The following is a description of a gene set: species: Homo sapiens Human Gene Set: MIR548AR_5P Genes predicted to be targets of miRBase v22 microRNA hsa-miR-548ar-5p in miRDB v6.0 with MirTarget v4 prediction scores > 80 (high confidence targets). from publication Chen Y, Wang X (PMID 31504780), and this is the list of marker genes: SLC24A3, ADGRB3, LRRC7, ERC2, TMEM200A, SCN3A, BTG3, PTBP3, RAB8B, ZNF559, TMEFF2, UNC80, BBS10, NRG4, SKIDA1, RAB27B, RNF149, ZNF652, C5orf24, SAMD8, NFKB1, PCDH11Y, ZNG1F, ZBTB41, SCML2, ANAPC1, MMUT, LSAMP, KRT28, TTC13, MTFR1 (NCBI Gene Id 9650), SLC30A5, EPHA3, NEGR1, BEND7, DIP2B, FSBP, TFDP3, DYNC1I2, CHN1, MBNL2, GASK1A, NUP50, ZBTB11, ATXN7L1, SDC2, SREK1, SH3D19, LPP (NCBI Gene Id 4026), CD163, ZNF326, RNF217, ADH5, DCDC2, GPALPP1, CBFB, PPARG, CYBRD1, FNIP2, NAV2, CA8, GLIPR1, ARRDC4, SEC24A, ZDHHC2, CCDC47, TTC19, TFAM, LACTB2 (lactamase beta 2), ZNF747, ACTN4, RO60, HDAC9, ZEB2, PRKAA2, KIF20B, MEIS2, PAX5, NDC1, IKZF2, FAM133A, ZBTB44, SERINC5, DAAM1, CLCN4, RGPD6, GATM, U2SURP, HECA, ZFAND5, MIER1, SLAIN1, GSTCD, TRPC1, TRAM1, FNDC3B, ZNF608, CCNY (NCBI Gene Id 219771), FGFR1OP2 (NCBI Gene Id 378428), PTGFRN, MIGA1 (NCBI Gene Id 374986), SYTL5, CRIPT, CLVS2, KLF8, RIC1, GPR85, RGS7BP, CFDP1, ZBTB20, STEAP2, MAST4, CEP120, TMEM167B, AK3, SFMBT1, CTNNA3, ITGAV, SDE2, FZD7, CEP350, AGTR1, SCN1A, MTA1, UBE2A, JARID2, SMG1, ZNF148 (zinc finger protein 148), MAML1, GPATCH11, ABI3BP, ETF1, ZRANB2, LRP1B, FGF12, LANCL1, NDFIP2, APPBP2, EPB41L5, SACS, KLF10, BTG2, ATXN2, TRUB1, TRA2B, ZBTB10, WAPL, GOPC, RORA, MAP9, PGAM1, ME1, FGD4, DENND1B, MGARP, C11orf87, DUS4L (NCBI Gene Id 11062), A1CF, TMEM135, SANBR (NCBI Gene Id 84542), PAQR9, SESTD1, RBBP8, WDR7, SERINC3, MYCN, ANKRD10, CCDC117, MIDEAS, ZNG1E, NRXN1, CHST9, C3orf38, SPATA6L, GABPB1, PCLO, CSNK1D, UGDH, NOS2 (nitric oxide synthase 2), TNFRSF21, PITX2, PROK2, WDR26, PLEKHG1, CCNG2, METTL8, MBIP, CCDC50, DYNC1LI2, MARCHF6, ODAPH, PIWIL3, MINDY2, PRKG1, LACTB, DHRS1, KLRD1, LMCD1, ZBTB25, RESF1, ZNG1C, PSMC2, PRPF40A, AP1AR, CLDN12, CAMLG, FZD5, WDR47, ZNF503, CAMSAP2 (NCBI Gene Id 23271), CNTN1, ZNF492, HOMER1, DTWD2, TRPC5, TOLLIP, ACVR2B, SDF4, HNRNPDL, SENP1, SETD2, UGT8, LRRC4B, SF3A1, ARL6IP6, NOTUM, CISD2, FIGN, SOX5, S1PR1, PRKAA1, OAZ1, B3GALT5, ARL13B, REV3L, STYX, SNX16, SECISBP2L, CD99, MIER3, MMD, RAP2A, SYNM (synemin), TCF12, LIN7A, NCKAP1, KLF7, BTF3L4, SRSF6, TMEM255A, ABCA5 (ATP binding cassette subfamily A member 5), ANGEL2, SNAP91, LVRN, SNX30, GRIP1, PROSER1, FZD3, NTF3, CCNB1, DOLPP1, THSD7A, ARID2, GSE1, SCN8A, SEC22C, URI1, FBXL3, GAPVD1, RETREG1, ARMCX3, PTPRG, RRAGD, PRP4K, ZNF454, TMTC3, ZNF680, PDE1C, HOXD13, PRKAG2, DEFA6, DPY19L3, FEM1C, PPP1R2, PDZRN4, FAM117B, HMBOX1, PRPF39, GCNT1, RMND5A, OGFRL1, CCP110, C21orf91, HOOK3, IGF1, METTL6, ACBD5, LARP4, SMAD5, TIFAB, EIF2AK2, NAA30, ZC3HAV1L, PGRMC2, AHSA2P, SCARF1, CMPK2, C6orf120, LCTL, PRELID2, PPP5C, EDIL3, CAPN2, FAM135A, UBA6, PTPRR, ADAM30, SCAMP1, RGPD8, PLEKHH2, ACAT2, BOD1L1, SLU7, GPR155, RAP1A, ANXA2, C9orf40, ZNG1A, SRP9, FYB2, SPDYE1, SLCO5A1, CHRNA7, ELL2 (elongation factor for RNA polymerase II 2), TP53INP1, PHYHIPL, CFAP44, FAM199X, YIPF5, SFT2D1, AIDA (axin interactor, dorsalization associated), MTF1, EVI2A, BBX, HLTF, POU2F1, MZT1, MAST3, CRACD, SSR3, SPOCK3, TBCA, ZDHHC15, HIPK1, FLRT3 (fibronectin leucine rich transmembrane protein 3), PAPOLG, KL, PPEF2, CIAO2A, TLCD4, ANKRD46, EEA1, GUCY1B1, SLC4A7, RALA, ACBD3, SAMTOR, NEDD4L, FOXG1, RICTOR, GNAQ, CACNA2D3, ACADL, NR2C1, ARK2N, RIMOC1, MEX3D, DNAJB14, HTR2C, MDFIC, ADAMTS1, GRID2, ZNF486, ZCCHC8, MFN1, LCOR, GPD2, IKBIP, SMAD9, SRSF3, DNAJB4, COL11A1, CERS6, CARF, GABRA4 (NCBI Gene Id 2557), ZDHHC21, NUMB, DIAPH3, XPNPEP1, RHOQ, KATNBL1, PPP1R27, ADAMDEC1, LMX1A, TMTC1, AQP3, ANKRD26, KPNA4, PCDH11X (protocadherin 11 X-linked), TRIM9, PREX2, IGF2BP3, CCSER1, TBCK, CCDC179, BRWD3, RFC3, KIAA1586, TPM3, MAGT1, GTF3C3, DUSP7, BNIP3, FMNL2, NAT1, EXOC5, MTMR6, UEVLD, TXLNG, GABPA, SIX4, MCF2L2, PPP1R9A, GOLGA6L2, PDCD5, NOTCH2, BCL2L2, FAM221A, NUP54, POLR2H, PRRC1, DUT, FGL2, NUP160 (NCBI Gene Id 80116), RFX7, GULP1, ANKRD22, CFL2, ADAM22, UTP3, CSGALNACT2, MFSD8, ASB3, MBNL3, PDE4D, ALG11, STXBP5, GRM7, IGSF3, CDK6, RHPN2, BMI1, LRRTM3, ZNG1B, RNF138, ARFRP1 (NCBI Gene Id 149661), CSTF2T, GCC2, FRMD5, SPAG9, CACUL1, MED6, RC3H1, ONECUT2, GPC6, ATP11A, RGPD4, AFDN, RGPD5, GUCY1A2, MAP4K4, CBX3, ITGB6, MMP16, LATS1, SUMF1, RASGRP1, TMED7, AFTPH, KCNJ3, NFAT5 (NCBI Gene Id 10725), COMMD3-BMI1, DDIT4, RASSF8, RPS6KA5, TMEM65, BRWD1, GRM5, TRIM2, MECP2, PPHLN1, ZNF792